The following is a description of a gene set: Mouse Gene Set: CUI_T_CELL_GD_IFNE_RESPONSE_UP Cytokines mediate cell-cell communication in the immune system and represent important therapeutic targets. A myriad of studies have highlighted their central role in immune function, yet we lack a global view of the cellular responses of each immune cell type to each cytokine. To address this gap, the authors created the Immune Dictionary, a compendium of single-cell transcriptomic profiles of more than 17 immune cell types in response to each of 86 cytokines (>1,400 cytokine-cell type combinations) in mouse lymph nodes in vivo. A cytokine-centric view of the dictionary revealed that most cytokines induce highly cell-type-specific responses. For example, the inflammatory cytokine interleukin-1β induces distinct gene programmes in almost every cell type. A cell-type-centric view of the dictionary identified more than 66 cytokine-driven cellular polarization states across immune cell types, including previously uncharacterized states such as an interleukin-18-induced polyfunctional natural killer cell state. Genes positively differentially expressed in cell type: γδ T cell upon treatment with cytokine: IFN-ε in mouse lymph nodes in vivo. from publication Cui A, Huang T, Li S, Ma A, Pérez JL, Sander C, Keskin DB, Wu CJ, Fraenkel E, Hacohen N (PMID 38057668) studied in species Mus musculus, and this is the list of marker genes: Slfn5, Mndal, Zbp1, Ly6e, Ccnd2, Rnf213, Rtp4, Herc6, H2-T23, Helz2, Ifi206, Gbp9, Oas3, Irf7, Isg20, Slfn8, Epsti1 (epithelial stromal interaction 1), Psmb8, Eif2ak2, Irgm1, Shisa5, Parp14, Ly6a, Samd9l, Xaf1, Parp9, Igtp, Ifit3, Tmbim6, Trim30a, Ifi203, Ifi27l2a, Psme1, Isg15, Tapbp, Ifi213, Stat1, Ifit1, B2m, Lgals3bp, Psme2, Bst2